The following is a description of a gene set: studied in species Homo sapiens Any process that modulates the frequency, rate or extent of aerobic respiration. Human Gene Set: GOBP_REGULATION_OF_AEROBIC_RESPIRATION, and this is the list of marker genes: CBFA2T3, SLC25A33, TNF (NCBI Gene Id 7124), UQCC2, SHMT2, VCP, NOP53, ISCU, TRPV4, ATP7A, IDE, ABCD1, MIR210, TMEM135, SLC25A23, MACROH2A1, SIRT3, AK4, RHOA, TEFM, MLDHR, ARL2, PARK7 (Parkinsonism associated deglycase), NUPR1, ACTN3, DNAJC15, PINK1, MLXIPL, PPIF, ETFRF1, SNCA